The following is a description of a gene set: DNA methylation is essential for normal development and has been implicated in many pathologies including cancer. Our knowledge about the genome-wide distribution of DNA methylation, how it changes during cellular differentiation and how it relates to histone methylation and other chromatin modifications in mammals remains limited. Here we report the generation and analysis of genome-scale DNA methylation profiles at nucleotide resolution in mammalian cells. Using high-throughput reduced representation bisulphite sequencing and single-molecule-based sequencing, we generated DNA methylation maps covering most CpG islands, and a representative sampling of conserved non-coding elements, transposons and other genomic features, for mouse embryonic stem cells, embryonic-stem-cell-derived and primary neural cells, and eight other primary tissues. Several key findings emerge from the data. First, DNA methylation patterns are better correlated with histone methylation patterns than with the underlying genome sequence context. Second, methylation of CpGs are dynamic epigenetic marks that undergo extensive changes during cellular differentiation, particularly in regulatory regions outside of core promoters. Third, analysis of embryonic-stem-cell-derived and primary cells reveals that 'weak' CpG islands associated with a specific set of developmentally regulated genes undergo aberrant hypermethylation during extended proliferation in vitro, in a pattern reminiscent of that reported in some primary tumours. More generally, the results establish reduced representation bisulphite sequencing as a powerful technology for epigenetic profiling of cell populations relevant to developmental biology, cancer and regenerative medicine. Genes with high-CpG-density promoters (HCP) bearing histone H3 trimethylation marks at k4 (H3K4me3) and K27 ((H3K27me3) in neural precursor cells (NPC). Human Gene Set: MEISSNER_NPC_HCP_WITH_H3K4ME3_AND_H3K27ME3 from publication Meissner A, Mikkelsen TS, Gu H, Wernig M, Hanna J, Sivachenko A, Zhang X, Bernstein BE, Nusbaum C, Jaffe DB, Gnirke A, Jaenisch R, Lander ES (PMID 18600261) species: Mus musculus, and this is the list of marker genes: SOX1, NEFL, ERBB3 (erb-b2 receptor tyrosine kinase 3), NDRG1, CBLN1, NRARP, GAD1, GPC5, FBXO43, FGF5, CSMD1 (CUB and Sushi multiple domains 1), WDR20, CCNO (NCBI Gene Id 9998), EPHA2, SLC35F2, COL27A1 (collagen type XXVII alpha 1 chain), MAP3K9 (NCBI Gene Id 4293), CELSR3, AK5, TUBA4A, SLC24A4, CAMKK1 (NCBI Gene Id 84254), PLEKHG3, GNAL, BHLHE22, CHST8, GRM8, ETNK2, MYO1D, ATOH1, RASSF5, ATP7B, KCNH3, GPAT3, CDS1, GDF6, ICA1L, RNF152, EFCC1, KLHDC8A, RASGEF1B, SATB1, JPH1, INF2, FHL2, DLL4, NEUROG2, NEUROG1, TEAD4 (TEA domain transcription factor 4), KIF26B, TSPAN18, RAB15, ADAMTS8, PCDH8, ABLIM2, RELN, ARHGAP44, ST8SIA2, FGF19, CLDN23, FOXB1, COCH, DISP3, ESRRB, FGF11, B4GALNT3, FGF9, NTNG1, NMNAT2, EPHA10, GREM1, LMO2, CDH22, PDE4A, ADRA2A, ARG2, SLC35D3, WNK2 (NCBI Gene Id 65268), VSTM2B, STK32C, FLT1, NPPC (natriuretic peptide C), EOMES, KCNMA1, GPRC5C, CHRNA5, GCH1, SYNM, VGF, CXCL12, KNDC1, KIF5C, HCN4, EMB, ADRA2B, MNX1, SFI1, KANK4, NXPH4, ANKRD33B, MAPK8IP2, PLXNA4, FOXO6, ELMOD1, UNC5A, SLC24A2, IGF2BP2, EGR4, PTPRU, TUB, GPR45, MEGF11, ATOH8, INA, PLTP, PITX2, CCDC85A, ADORA2B, NEFM, FRMD5, SMAD6, KIAA1549L, GALNT3, GPR88, KHDRBS2, WNT11, KCNJ4, ADORA1, P2RY2, RGS9BP, RSPO2, SH3RF3, TENM4, CDKN1A, HOXC4, ELFN1, CWC22, EPB41L1, PLAG1, PTPN5, RAB20, TMTC4, BMF